Given this list of marker genes IGKV2-29, BRMS1, PLCG2, IGKV3-20, IGLC3, FXYD7, BLNK, IMPDH1 (NCBI Gene Id 6105), SAP30, ROCK2, ROCK1, ARID4A, IGKV2-30, RBBP7, SAP30L, SAP18, VAV1, REST, IFNAR1, IGLV1-44, IL6R, IGKV1D-39, IGLV2-8, IGKC, MTA2, ATP1A4, IGLV7-43, SYK, IGHV3-30, IGKV1D-16, FXYD4, IGHD, FXYD6, IGHV2-5, TBK1, IGHV3-7, AP2A2, BTK, ATP1B1, IGLV3-27, CYSLTR1, KEAP1, IGLC7, IGHV3-9, ARID4B, ATP1A2, JAK1, IGHV3-23, IGHV4-39, IGLV3-1, ITGA4, IGKV4-1, CHD4, IGKV1-12, RIPK1, VEGFA, CD79B, CUL3, JAK2, IGLV3-25, IGKV2D-30, IGHV1-46, SUDS3, AP2M1, MBD3, ATP1B2, IGHV1-69, GRB2, FNTB, NCK1, IGLV2-23, PHF21A, HDAC2, ATP1A3, IGHV3-11, FXYD2, TYK2, IGLV, RBX1, FURIN, IGLV6-57, IGLV3-19, TLR9, GATAD2B, IGHV, IGHV3-33, SIGMAR1, TUBB, STAT2, IGHM, KDM1A, HDAC1, IGKV3-15, IGHV2-70, IGKV2D-28, FXYD3, IGKV1-17 (immunoglobulin kappa variable 1-17), COMT, IGKV1D-12, IGHV3-48, IGHV7-81, IGLV1-47, AP2S1, NFE2L2, IGHV3-53, IGLV3-21, FKBP4, GATAD2A, IGHV1-2, IGKV5-2, IMPDH2, IGLC6, AP2B1, FKBP1A, IGKV1-39, TLR7, IGKV1-33, IGLV2-11, ITGB1 (NCBI Gene Id 3688), IL1R1, FXYD1, ATP1B3, S1PR1, SH3KBP1, IGHV3-13, SOS1, IGLC2, IGKV3D-20, IFNGR2, IGHV4-59, RBBP4, MTA3, NR3C1, IGLV1-51, CD79A, HSP90AA1, ZBP1, IGKV1D-33, IGKV2-28, IGKV3-11, IGKV1-5, JAK3, IFNAR2, PDCD1 (NCBI Gene Id 56179), IGLC1 (immunoglobulin lambda constant 1), BRD4, ACE2, AP2A1, CRBN, IGHV4-34, ATP1A1, HSP90AB1, IGKV1-16, NS5B, PTGES3, IFNGR1, MTA1, CHD3, HMG20B, IGKV2D-40, IGLV1-40, FNTA, RCOR1, IGLV2-14, here is a description of the gene set: species: Homo sapiens The search for drugs to prevent or reduce the severity of human infection with SARS-CoV-1 or SARS-CoV-2 has centered on ones that are effective in treatment of human infections with other RNA viruses or in diminishing cytokine storms and other pathologies due to destructive host reactions. The interactions of a large number of these candidate drugs with their known viral and human protein targets are annotated, as are some drugs that inhibit Cytochrome P450 (CYP) oxidoreductases to prolong the plasma half-lives of antiviral drugs. In addition, effects of these drugs on unrelated essential human proteins, that might limit their use in vivo, are annotated.<p>A notable success of this search is a combination treatment, Paxlovid (NCT04960202), involving ritonavir, an inhibitor of CYP3A4 and CYP2B6 oxidoreductases, and nirmatrelvir, an inhibitor of SARS-CoV-2 3CLp protease, to block steps in maturation of viral replicase proteins. part of: SARS-CoV Infections Reactome Pathway: Potential therapeutics for SARS